Given this list of marker genes ATXN2, GBA1, ATXN1, ATXN3, ATXN7, here is a description of the gene set: species: Homo sapiens A vertical gaze palsy with inability to direct the gaze of the eyes downwards. Supranuclear ophthalmoplegia Human Gene Set: HP_SUPRANUCLEAR_OPHTHALMOPLEGIA